The following is a description of a gene set: from publication Yevshin I, Sharipov R, Kolmykov S, Kondrakhin Y, Kolpakov F (PMID 30445619) Genes containing one or more binding sites for (SOD1) in their promoter regions (TSS -1000,+100 bp) as identified by GTRD version 20.06 ChIP-seq harmonization. studied in species Homo sapiens Human Gene Set: SOD1_TARGET_GENES, and this is the list of marker genes: SNORD12 (NCBI Gene Id 692057), SNORA32, GAS5, SNORD6, SNORA25